The following is a description of a gene set: Category B genes: p53-dependent genes whose expression in the absence of S389 phosphorylation is dissimilar to loss of TP53 in MEF (embryonic fibroblast) cells in response to UV-C irradiation. Human Gene Set: BRUINS_UVC_RESPONSE_VIA_TP53_GROUP_B Phosphorylation is important in p53-mediated DNA damage responses. After UV irradiation, p53 is phosphorylated specifically at murine residue Ser389. Phosphorylation mutant p53.S389A cells and mice show reduced apoptosis and compromised tumor suppression after UV irradiation. We investigated the underlying cellular processes by time-series analysis of UV-induced gene expression responses in wild-type, p53.S389A, and p53(-/-) mouse embryonic fibroblasts. The absence of p53.S389 phosphorylation already causes small endogenous gene expression changes for 2,253, mostly p53-dependent, genes. These genes showed basal gene expression levels intermediate to the wild type and p53(-/-), possibly to readjust the p53 network. Overall, the p53.S389A mutation lifts p53-dependent gene repression to a level similar to that of p53(-/-) but has lesser effect on p53-dependently induced genes. In the wild type, the response of genes to UV irradiation was strictly biphasic. The early stress response, from 0 to 3 h, results in the activation of processes to prevent the accumulation of DNA damage in cells, whereas the late response, from 12 to 24 h, relates more to reentering the cell cycle. Although the p53.S389A UV gene response was only subtly changed, many cellular processes were significantly affected. The early response was affected the most, and many cellular processes were phase-specifically lost, gained, or altered, e.g., induction of apoptosis, cell division, and DNA repair, respectively. Altogether, p53.S389 phosphorylation seems essential for many p53 target genes and p53-dependent processes. studied in species Mus musculus from publication Bruins W, Bruning O, Jonker MJ, Zwart E, van der Hoeven TV, Pennings JL, Rauwerda H, de Vries A, Breit TM (PMID 18195040), and this is the list of marker genes: TMEM53, IGF1R, TFRC, LTBP4, FAF2, CXCR6, GAS2L3, RELA, SMIM11, MXRA8, CCNA1, TGFB1I1, SERPINE2, LIF, CFAP61 (NCBI Gene Id 26074), JUP, GSDME, CNNM2, SULT2A1, SHC3, AKIRIN1, SLC50A1, RINL, COL4A2, MCUB, CCPG1, SLC35A1, SMIM15, NQO1, FHL3, ASB9, LOXL3, NR1I2 (NCBI Gene Id 8856), IL11, SPAG4, OSBPL5, KLF6 (NCBI Gene Id 8025), CELSR3, CEMIP, GADD45G, PRKCD, DNAJC22, POMGNT1, CD44, REEP6, THBD, MYADM, SDCBP2, TRMT10B, TNFRSF12A, DNAJB1, XDH, LRP1, FBXL3, DUSP6, LCE1C, TNFRSF11B, IVL, CRLF1, SEMA4A, OIP5, LYNX1, GJB6, SLC10A6, ITGAL, IL3RA, NFYC, S100A6, MGP, PRTN3 (NCBI Gene Id 5657), L3HYPDH, CD274, PRSS23, RAD54L, COL4A5, INHBA, BPIFA1, RASGEF1C, TMEM132C, SPP1, KLHDC8A, SP6, PHF19, DYNC1H1, YES1, CD59, FBRS, CLTB, STK11IP, PCDHB4, TRIM16, CGRRF1, TIMP4, TNFSF12, TRIM3, TRIM11, MAP2K3, DUSP14, COQ10B, TMSB4X, SYN2, AGA, BCL10, MFAP3L, IL6, HERPUD2, SERPINB5, SOX17, TCL1A, ZNF235, FADS2, ETNK1, MATR3, CHMP3, CAP1, ANO1, ROCK2, SLC35A2, MSRB1, KRT8, SGF29 (SAGA complex associated factor 29), NRDE2, SLC31A2, IL5RA, FOSB, BCL9, AMOTL2, RGS16, SCN1B, VASN, RASSF1, HPS1, ZNF3, COL4A1, TNFSF8, CHMP1B, UNC5CL, RASD2, HSPA1A, P2RX4, ADAM22, RNASE1, UNC5C, CITED1, PHACTR3, WIPI2, S100A4, MUC13, GNG11 (NCBI Gene Id 2791), RIMS1 (regulating synaptic membrane exocytosis 1), NPDC1, MGAT2, KDM7A, SMPD1, SND1, CTSF, PDRG1, GTF2IRD2B, ABCD4, SERINC1, COL17A1, GZMM, SPTLC1, ALDH3B1, FBXO6, DNAJC18, LCE1A, DDC, OR51B6, SULT1A1, CCN2, ZCCHC3, SOX1, SPRR1A, COL7A1, C5AR1, MFGE8, CISH, TRAF3IP2, TINAGL1, TEF, MT4, INMT, ASAH1, FBXO4, VN1R5, NRXN1, C1GALT1C1, AMOTL1, RNASE2, NKX2-8, EPHA2, FMO2, LRRC27, SFMBT1, GPR19, CILK1, RAB22A (RAB22A, member RAS oncogene family), PLA2G2E, AOX3P, SAT1, ABHD4, ART1, PAK2, COL10A1, SMAD7, JPH2, SLC1A1, GALNT14, SEMA3D, CASP8AP2, NR4A1, UTRN, CEP85L, GPR85, ALDH8A1, POLD4, BTG2, RGS18, CALU, APAF1, CHST6, AHNAK, FLYWCH2 (NCBI Gene Id 114984), NSMCE3, TSPAN13, CTSA, GRB14, SLC35E3, SYPL2, EDEM1, TEC, SLC20A1, ELOVL1, CRIP2, CCL8, NUAK2, GZMH, ABCB4, AJUBA, IL15RA, FMC1, PAPPA, NME6, SQSTM1, ULK1, HGSNAT, EPHX1 (epoxide hydrolase 1), PTK7, VNN3P, MAPK8IP1, C16orf87, DUSP1, ZNF688, PHYHD1, TMBIM1 (NCBI Gene Id 64114), AEN, EOLA1, HLA-DMA, BTG3, PNMT, AGRN, WDR31, MRAP, MCPH1, SHISA5, LTBP3, MRPS18B, SETD7, SLC48A1, WDR64, KRT4, LTB4R, SHD, INF2, PGLYRP1, MIPEP, FNDC4, LGALS8, CRCT1, OLIG2, CASP2, NFKB2, TCF21, DNAJC17, CYP46A1, RPS12, TMEM41B, LAPTM4B (lysosomal protein transmembrane 4 beta), DCXR, FAM217A, NOCT, PKD1, MMP3, NCR1, AKT1S1 (NCBI Gene Id 84335), WFS1, ARG2, RNF128, PRR5L (NCBI Gene Id 79899), EAF2, ALPK3, RYR3 (ryanodine receptor 3), SERPINB2, CCRL2, SEMA7A, TES, HOATZ, KRT71, APP, ANXA8L1, HAPSTR1, CHST14, SERPINE1, CHRNE, KEL, ACAD8, SNRPD3, LATS1, MLYCD, EYA4, THAP7, NOS1AP, INPP1, UCN3, AVPI1, SCN11A, HEXIM2, PMAIP1, POLK, FAM114A1, SNHG20, NABP1, PCDH8, ANXA1, FGF1, SH2B3, BET1L, REXO1, NKAIN4, HBEGF, ARX, TRMT11, FGFBP3, GASK1B, CGREF1, KIF15, ENO3, B4GAT1, SIDT2, H1-2 (NCBI Gene Id 3006), CCDC127, HYLS1, KLF16, MARVELD2, ATXN7, DYNLT3, DRAM1, GBA1, GAS5, PDGFRA, LRRFIP1, DTX1, FUCA1, PHTF1, RYR1, SERP2, CLEC10A (NCBI Gene Id 10462), CBS, CASTOR1, HOXD13, PGM3, PIGF, CPOX, PRPS1, HPD, RALGPS2, GPCPD1, TMEM216, CPEB1, EIF1 (NCBI Gene Id 1963), H3C14, UBQLN1, RSPO1, SGCD, SLC12A4, BHLHE40, CHPF2, OCIAD2, ANTXR1 (NCBI Gene Id 84168), RIN1, OR51B2, EREG, SRPK3 (SRSF protein kinase 3), RPE, LIX1, COPZ2, GGCT, FNBP1, ZWINT, PNCK, CFAP298, HCN3, MTTP, FOXA1, MFSD5, TSHB, F3, PLBD2, ALG5, BAG3, GPI, CRISP2, RENBP, NXF2B, PMEPA1, FAS, ADRB2, ERCC5, RAG2, RBP4, C19orf25, ADAM23, RAI14, PFKFB1, ANXA3, TMEM192, TIMP2, CENPN, IGHM, MVP, NFKBIZ, TPD52, TJP3, SAP30BP, SRXN1, HSD17B11, BMP1, EPYC, GOLGA7, GNA11, BMP2K, ENPP5, NGF, SYNC, IL10RB, ITPKC, UBXN6, OR13C7, GTF2IRD1, RASA4B, CAV2, NR6A1, ZFPL1, MYO6, ECHDC3, SORBS1, ARAF, TEAD3, NDRG4, RNF41, RFX4, NECTIN3, ZFAND2A, DEPDC7, TAP2, UBL4A, EBF3, VPS51, ALDH3A2, TRAPPC2, ZBTB49, BORCS6, OLR1, PTGS2, GPC4, FBXO25, CDKN2D, CMTM6, HACD1, RPAP3, CHPF, CCDC3, YIPF6, SP5, MYD88, DFFA, UBE3D, SPARC, HASPIN, PICALM, PLSCR3, GSS, SHISAL2B, EPHA3, C11orf24, NMI, TEX261, GABRB2, LAMB3, METTL6, MMP14 (NCBI Gene Id 4323), HTATIP2, PIK3IP1, PLAUR, PLK3, PIGM, ACKR1, RAB23, NCAN, CFL2, PLD3, GRIA3, PIAS1, MSX2, MORN5, P2RX3, LRRIQ4, CHMP1A, IFT25, ANGPTL2, FRMD6 (NCBI Gene Id 122786), C15orf39, METTL21A, MFAP2, CCN3, KLHL21, SPINK9, LCN2, FAM20A, GCC1, PACSIN1, ZNF821, BDH2, AREG, QSOX1, UPF3A, STK4 (serine/threonine kinase 4), DDAH2, MAFK (MAF bZIP transcription factor K), NINJ1, LRRC51, SLC23A1, TSPAN17, CCN4, MCFD2, WDR90, COL5A3, SMIM12, RAB21, ETS1, RRAS2, ZG16B, GINM1, ZBTB41, AEBP1, SH3GL1